Given this list of marker genes Nog, Lrrn4 (NCBI Gene Id 320974), Ghrl, Gnat1, Adra1b, Hif1a, Sct, Cck, Hrh2, Ppp1r1b, Braf, Abcc8, Nps (neuropeptide S), Ddhd2, Abl2, Drd1, Dcdc2a, Drd3, Meis2 (NCBI Gene Id 319479), Neto1, Slc7a11, Pianp, Crhr1 (corticotropin releasing hormone receptor 1), Deaf1, Pde8b, Idua, Drd2, Synpo, Creb1, Tuba1a (NCBI Gene Id 22142), Gnat2, Pias1, App, Dbh, Hoxa1, Kit, Itgb1, Nlgn3, Grin1, Ap1s2, Ttc36, Foxb1, Chrd, Comt, Ckap5, Cdk5, Zzef1, Hmgcr, Nptn, Rag1, Syngap1, Kras, Atxn1, Atp1a3, Nf1, Slc1a2, Chrnb2, Atp1a2 (ATPase, Na+/K+ transporting, alpha 2 polypeptide), Rgs14, Dynlrb1, Opn4, Nts, Ric8a, B3gat1, Pde1b, Tafa2, Abca7, B4galt2, Hrh1, Kmt2a, Ndrg4, Cacna1c, Drd5, Tanc1, Ctns, Mecp2, Sgk1, Mtor, Cacna1e (NCBI Gene Id 269133), Adam2, Pln, Htt, Ift20 (intraflagellar transport 20), Grin2a, here is a description of the gene set: The behavior of an organism in response to a visual stimulus. Mouse Gene Set: GOBP_VISUAL_BEHAVIOR studied in species Mus musculus